Given this list of marker genes ENSG00000230746, OR2AO1P, RN7SL456P, OR2A2, RNU6-1184P, OR2A9P, OR2A14, OR2A5, OR10AC1, TAS2R60, PPIAP83, OR2A1, MIR548F4, CAPZA1P5, RNU6ATAC40P, PAICSP6, TCAF1, EEF1A1P10, TCAF2P1, OR2A1-AS1, OR2A3P, EPHA1, TAS2R62P, RANP2, ARHGEF34P, RNU6-267P, SLC16A1P1, CTAGE4, OR2R1P, ENSG00000291149, TAS2R41, ENSG00000230190, DUTP3, TCAF2, CTAGE8, CNTNAP2, OR2A15P, OR2A7, DPY19L4P2, OR2A41P, OR2A20P, ARHGEF35-AS1, OR2A12, OR2F2, TCAF1P1, OR2A25, OR2A42, ARHGEF35, RNU6-162P, RN7SKP174, RPL7P59, TPK1, ARHGEF5, PAICSP5, EI24P4, CTAGE6, OR2Q1P, NOBOX, OR6B1, ENSG00000309129, CTAGE15, TCAF2C, OR2F1, EPHA1-AS1, RNA5SP249, OR2A13P, CNTNAP2-AS1, here is a description of the gene set: Human Gene Set: chr7q35 studied in species Homo sapiens